Given this list of marker genes NR1H3, NUAK1, MYOM3, TACC2, PCP2, SESTD1, HRCT1, ASAP2, SCTR, SFXN2, DLX2, RAB26, ORM2, XKR6, DHX37, DACT3, DNAI1, SLCO2A1, GPR152, PRR5L (proline rich 5 like), PCYT1B, POU4F3, PDZD4, CRYGN (NCBI Gene Id 202871), GHRL, IL36RN, TMEM52, FILIP1L, BMERB1, SCGB1A1, SLC6A1, CDH18, ZNF423, DNAAF4 (dynein axonemal assembly factor 4), CBY2, WASF3, DDB2, CRYBB3, SLC17A7, PNLDC1 (NCBI Gene Id 154197), SLC2A2, STAU2, TSPAN17 (NCBI Gene Id 89852), SLC45A3, WDR53, GNAT1, MEGF10, THBD, CD276, PTN, PDE3A, HGF, GGN, CST6, ADAM32, HEPACAM, TMEM17, SYDE1, RAB30, RFX8, PHETA1, BEX1, CCN6, AGRP, ATP6V1E2, SPAG1, KDM3A, ZWILCH, PHYHIP, RGS16, DNAJB7, MFSD3, ANTXR1, TCHHL1, NRP1, SDC1, CCN4, ADGB, RYR3, B3GAT2, SPOCK3, BNIPL, TRMT10A, TRAIP, CFAP96, KCNV2, DIRAS2 (DIRAS family GTPase 2), COL4A4, LPCAT2, RLBP1, KIF6, TEKT3, TET1, CCL7, RUFY2 (NCBI Gene Id 55680), CDH6, ESR1 (NCBI Gene Id 2099), CCDC62, NECAB1, ITIH1, MBOAT4, NSG1, NFE2, PCSK1N, C16orf90, HSPB2, LACTBL1, EIF2A, PRG2, APOF, KRT8, SIPA1L2, CFD, CA13, NACAD, ECRG4, THOC1, PHACTR2, GLIS1, PRR27, EPHX4, POMGNT2, CKMT1B, BEST1, TMEM178A, SPESP1, CNGA2, GYS2, RHPN1, NANOS1, ZNF141, LMCD1, IGFBPL1, CCDC39, CCL17, CC2D2B, MYF6, SCG2, LRRN2, SPRY3, PRR14, LZTS3 (NCBI Gene Id 9762), PKP4, CD209, FLRT3, PLEKHN1 (pleckstrin homology domain containing N1), PIP5K1B, CLDN6, SCNN1G, LIPC, SPATA17, TMEM132A, MMP3, EMP2, NPHS1, CFAP119, C16orf46 (chromosome 16 open reading frame 46), EFNA5, ADAMTS5, RAD54B, ZBTB49, MAGEB5, NKAIN4, VIP, SNX31, PTPRM, NLRP6, NGF, GNGT1, SCN10A, MORC4, CARMIL3, NRSN1, MMRN2, STMN3, PITX2, PTPN5, PPP1R26, ZDBF2, FBXO16, KRT33A, MORC3, DDAH1, ACTL7A, TNN, CYBRD1, VKORC1L1, PTPN13, GABRA2 (gamma-aminobutyric acid type A receptor subunit alpha2), SULT4A1, CHI3L1, CYP2U1, SYCP2L, ARHGAP8 (Rho GTPase activating protein 8), TMEM89, HSD17B6, MTRF1L, MTCL2, TMEM212, here is a description of the gene set: Genes down-regulated in comparison between in vivo derived natural T reg (nTreg) and converted ex-iTreg (induced T reg that lost FOXP3 expression). from publication Schmitt EG, Haribhai D, Williams JB, Aggarwal P, Jia S, Charbonnier LM, Yan K, Lorier R, Turner A, Ziegelbauer J, Georgiev P, Simpson P, Salzman NH, Hessner MJ, Broeckel U, Chatila TA, Williams CB (PMID 23125413) Human Gene Set: GSE35543_IN_VIVO_NTREG_VS_CONVERTED_EX_ITREG_DN species: Homo sapiens Induced Treg (iTreg) cells are essential for tolerance and can be used therapeutically, yet their stability in vivo and mechanisms of suppression are unresolved. Here, we used a treatment model of colitis to examine the role of autologous IL-10 in iTreg cell function. Mice treated with IL-10+/+ iTreg cells in combination with IL-10–/– natural Treg (nTreg) cells survived and gained weight, even though iTreg cells were numerically disadvantaged and comprised just ~20% of all Treg cells in treated mice. Notably, ~85% of the transferred iTreg cells lost Foxp3 expression (ex-iTreg) but retained a portion of the iTreg transcriptome which failed to limit their pathogenic potential. The TCR repertoires of iTreg and ex-iTreg cells exhibited almost no overlap, which indicates that the two populations are clonally unrelated and maintained by different selective pressures. These data demonstrate a potent and critical role for iTreg cell produced IL-10 that can supplant the IL-10 produced by nTreg cells and compensate for the inherent instability of the iTreg population.